The following is a description of a gene set: CSF pleocytosis An increased white blood cell count in the cerebrospinal fluid. studied in species Homo sapiens Human Gene Set: HP_CSF_PLEOCYTOSIS, and this is the list of marker genes: UNC93B1, SLC13A3, TREX1, UNC13D, PRRT2 (NCBI Gene Id 81865), PRF1 (NCBI Gene Id 5551), LSM11, IFIH1 (NCBI Gene Id 64135), RNASEH2A, SCN1A, TLR3, NOTCH2NLC, CACNA1A, STX11, TBK1, RNASEH2C, STXBP2, RNU7-1, CMPK2, RNASEH2B, ADAR, IRF3, FAS, ATP1A2, PTPN22, SAMHD1, TICAM1, TRAF3